Given this list of marker genes CCT6A, FABP5, HSP90B1, TNFRSF9, TNIP2 (NCBI Gene Id 91017), CALR, CCT2, RANBP1, ILF2, SNRPE, SNRPD1, NOP16, EIF5A (NCBI Gene Id 1984), TIMM13, IMPDH2, BANF1, GTF3C6 (NCBI Gene Id 112495), FBL, DCTPP1, PRDX1, VDAC1, PARK7, ATP5MC1, C1QBP, NDUFAB1, NME1, PGAM1, PPA1, BATF, HSP90AB1, ENO1, PKM, CRTAM, CXCL13, CCT5 (chaperonin containing TCP1 subunit 5), BIRC3, TNFRSF18 (NCBI Gene Id 8784), NFKBIA, PHB1, XCL2, LSM5, DNPH1, NHP2, TXNDC17, PRMT1, RAN, EIF3I, XCL1, DUT, SEC11C, here is a description of the gene set: Human Gene Set: GAVISH_3CA_METAPROGRAM_CD8_T_CELLS_GLYCOLYSIS_MYC In this study, an extensive analysis was conducted to define meta-programs (MPs) capturing intra-tumor heterogeneity across a spectrum of tumor types. The approach utilized non-negative matrix factorization (NMF) to analyze each cell type separately within individual tumor samples. This involved the analysis of malignant cells, macrophages, fibroblasts, endothelial cells, epithelial cells, T-cells, and B-cells. NMF was executed with varying parameter values (K=4, 5, 6, 7, 8, 9), thereby generating 39 programs for each cell type per sample. Each NMF program was summarized by the top genes based on NMF coefficients.\nRobust MPs were then delineated for each cell type using a set of stringent criteria, including recurrence within the same tumor, similarity to programs in other tumors, and non-redundancy within a tumor. Subsequently, these robust NMF programs were clustered (per cell type) based on Jaccard similarity, leading to the identification of MPs associated with each cell type.\nTo enhance the quality of the MPs, a refinement steps were undertaken, involving the removal of MPs suspected of reflecting low-quality data (with an overrepresentation of ribosomal proteins or mitochondrial-encoded genes), single-study inclusion, or similarity to miss-annotated cell types. Genes upregulated in subsets of cells of a given type within various tumors from publication Gavish A, Tyler M, Greenwald AC, Hoefflin R, Simkin D, Tschernichovsky R, Galili Darnell N, Somech E, Barbolin C, Antman T, Kovarsky D, Barrett T, Gonzalez Castro LN, Halder D, Chanoch-Myers R, Laffy J, Mints M, Wider A, Tal R, Spitzer A, Hara T, Raitses-Gurevich M, Stossel C, Golan T, Tirosh A, Suvà ML, Puram SV, Tirosh I (PMID 37258682) species: Homo sapiens